The following is a description of a gene set: Reactome Pathway: Pexophagy part of: Selective autophagy studied in species Homo sapiens Peroxisomes are cytosolic organelles involved in the catabolism of branched and long-chain fatty acids and in the reduction of reactive oxygen species (ROS). Peroxisomes homeostasis is critical to maintain ROS levels. Consequently, it is important to eliminate dysfunctional peroxisomes. The degradation of peroxisomes by autophagy is known as pexophagy (Katarzyna ZR et al. 2016). Pexophagy can be triggered by a shift in nutrient conditions., and this is the list of marker genes: UBB, UBC, SQSTM1, RPS27A, USP30, MAP1LC3B, EPAS1, ATM, PEX5, UBA52, NBR1